The following is a description of a gene set: Human Gene Set: PID_S1P_S1P2_PATHWAY S1P2 pathway studied in species Homo sapiens from publication Schaefer CF, Anthony K, Krupa S, Buchoff J, Day M, Hannay T, Buetow KH (PMID 18832364), and this is the list of marker genes: MAPK14, PAK1, S1PR2, JUN, RHOA (ras homolog family member A), MAPK1, GNAQ, GNA13, GNA11, GNAI2, MAPK3 (NCBI Gene Id 5595), GNAZ, CDH5, FOS, GNAI3, IRS1, GNAI1, GNA15, MAPK8, ELK1, RAC1, GNA14, GNAO1, GNA12